The following is a description of a gene set: Genes up-regulated in effector CD8 T cells: CXCR1+ versus CXCR1-. Human Gene Set: GSE26890_CXCR1_NEG_VS_POS_EFFECTOR_CD8_TCELL_UP Effector CD8+ T cells are believed to be terminally differentiated cells having cytotoxic activity and the ability to produce effector cytokines such as INF-γ and TNF-α. We investigated the difference between CXCR1+ and CXCR1- subsets of human effector CD27-CD28-CD8+ T cells. Both subsets similarly expressed cytolytic molecules and exerted substantial cytolytic activity, whereas only the CXCR1- subset had IL-2 productivity and self-proliferative activity and was more resistant to cell death than the CXCR1+ subset. These differences were explained by the specific up-regulation of CAMK4, SPRY2, and IL-7R in the CXCR1- subset and that of pro-apoptotic DAPK1 in the CXCR1+ subset. The IL-2 producers were more frequently found in the IL-7R+ subset of the CXCR1- effector CD8+ T cells than in the IL-7R- subset. IL-7/IL-7R signaling promoted cell survival only in the CXCR1- subset. The present study has highlighted a novel subset of effector CD8+ T cells producing IL-2 and suggests the importance of this subset in the homeostasis of effector CD8+ T cells. species: Homo sapiens from publication Takata H, Naruto T, Takiguchi M (PMID 22174157), and this is the list of marker genes: DLL1, RIGI, PNPT1, ZBP1, VSTM5, HASPIN, MIDEAS, DAXX, PMEPA1, ATG12, PPA1, NT5C3A, RNF213, NFATC1, IRF7, IFIT1 (NCBI Gene Id 8374), CLDND1, MED12L, HMGN3, APPBP2, FDFT1, INPP4B, DPP4 (NCBI Gene Id 1803), PI4KB, ESF1, LSS, MX2, NLRC5, SAMHD1, DECR2, G3BP2, STAT1 (NCBI Gene Id 6772), FBXO34, OGFRL1, DNAJC13, HSH2D, EVI2A, AP4E1, NIBAN1, MBTD1, TDRD7, AIDA, GBP2, DDX60, PTGES3, MTDH, OXSR1, PACC1, LYN, SLF2, COX18 (NCBI Gene Id 285521), CAMKK2, DTX3L, PABPC1, CD274, BICRAL, CD86 (NCBI Gene Id 942), MGST2, SERPINB9 (serpin family B member 9), PLAC8 (NCBI Gene Id 95621), ZSCAN29, MARCHF5, TMEM140, LPXN, OAS2, IFIT1B, SPATA13, USP18, ITCH, CD47, XDH, IRF1, RTP4, GBP7, NAA20, MRPL1, IFI44L, XAF1 (XIAP associated factor 1), UTP14A, COX15, OASL, TRIM34 (tripartite motif containing 34), OAS3, USP25, ABTB2, SCIN, TM9SF1, PHIP, KHSRP, CCRL2, RSL24D1, SLFN5, MPEG1, ASB13, IFIT2, CAPRIN1, PURA, LARP1, EIF2AK2, CEP295, VCPIP1, GBP6, EXOC4, SLFN13, RSAD2, ELF1, STARD4, PARP11, OAS1, RNPS1, PARP14, UBXN2B, TNFSF10, SQLE, ANKRD12 (ankyrin repeat domain 12), ZEB2, TRAFD1, URI1, TOR3A, NOL7, PARP12, SCO1, CNOT3, TUT4, IFI44, RILPL1, MREG, NCOA7, AXL, BCL2A1 (NCBI Gene Id 597), CCAR2, CRAMP1, RNASEL, TLR3, TOMM70, TET2, INSIG1, EHD3, NCEH1, MLEC, MRFAP1L1, ZNF277, ZUP1, CYBB, CARMIL1, SLFN12, CHD7, FOXP1 (forkhead box P1), MFSD8, ANKLE2, GTF3C2, EPSTI1, NIT2, KBTBD2, TLR7, CFAP210, IFITM3, SHISA5, HAP1, ISG20, DEK, FAP, SETDB2, CXCL10, LPAR6, HERC6, LGALS3BP, BAZ1A, CCDC171, CCDC25, INPP1, HEG1, TMEM185A, PELI1, PML, NAMPT, CSDE1, AGRN, SAMD9L, CGAS, CCNL1, CNOT6L, IFIH1, CPSF2, MBD5, ZC3H11A, WLS, TRIM21, HLA-E (major histocompatibility complex, class I, E), ISG15, TTC39B, PARP9, IDI1, MRPL22, IRF9, GYPC, SGCB (sarcoglycan beta), CALHM6, MITD1, CMPK2